The following is a description of a gene set: Bluish-grey, spongy nodules associated with scars over pressure points and easily traumatized areas like the elbows and knees. Molluscoid pseudotumors Human Gene Set: HP_MOLLUSCOID_PSEUDOTUMORS studied in species Homo sapiens, and this is the list of marker genes: COL1A1, COL5A1, ZNF469, AEBP1, COL3A1, PLOD1 (procollagen-lysine,2-oxoglutarate 5-dioxygenase 1), COL5A2